The following is a description of a gene set: studied in species Homo sapiens Human Gene Set: MIR7843_3P from publication Chen Y, Wang X (PMID 31504780) Genes predicted to be targets of miRBase v22 microRNA hsa-miR-7843-3p in miRDB v6.0 with MirTarget v4 prediction scores > 80 (high confidence targets)., and this is the list of marker genes: HDAC2, OMG, BET1, AP1G1, BHLHE40, ROBO1, RIMS1, ADGRF5, TASOR (transcription activation suppressor), FIBIN, LRRN3, EXD2, VWC2L, PRKRA (protein activator of interferon induced protein kinase EIF2AK2, NCBI Gene Id 94716), DYNC1LI2, ZFYVE28, RHEB, MYO16, TMEM258, ZNF676, SLC9A2, ADRA1A, MOBP, COL8A1, PRP4K, CNOT7, FBXW11, GNRHR, SYNPO2L, BACE1, TBX6, SNX31, STXBP5, USP9X, RDX, APPL1, DIPK1A (divergent protein kinase domain 1A), MRPS5, SESTD1, TTN, CCDC6, TNKS, PIK3R1, INA, SGK2, CD164, KRTAP19-6, KDM5A, SATB2 (SATB homeobox 2), GAS2L3, RCC1, PTGES3, NEPRO, SLC47A2, CTNND2, PA2G4, MIA3, GOPC, CCDC28A-AS1, SLC23A2, RALA, ONECUT2, TMEM178B, PSMC2, PIGN, TEX35, KLHL13, SNCA, IGSF3, MFAP3, BAZ2B, GFRA2, ENPP1, NWD1, RRAGA, DCTN3, RGS7BP, CTTNBP2NL (CTTNBP2 N-terminal like), GREM1, ACYP2, SV2C, QSOX2, WT1, TNIP1, HDGFL3, H2AZ1, DCUN1D1, GATM